The following is a description of a gene set: species: Homo sapiens Human Gene Set: chr9q21, and this is the list of marker genes: SNORA70, PCA3, LINC02872, RN7SL570P, DPP3P2, ASS1P3, RNU6-1035P, RPL24P8, BANCR, GNA14-AS1, IGKV1OR-3, LINC01507, HNRNPK-AS1 (HNRNPK antisense RNA 1), ENSG00000306036, FXN, RFK, RNU2-5P, ENSG00000227809, BMS1P13, TRPM6, RN7SL422P, ZNG1E, SPATA31A3 (SPATA31 subfamily A member 3), BMS1P12, RNU6-1303P, LINC03025, GKAP1 (G kinase anchoring protein 1), RNA5SP287, ZNF658, RN7SKP47, C9orf153, RNU6-820P, CYP1D1P, DAPK1-IT1, CYP4F59P, BTF3P4, RMI1, UBE2V1P10, GDA, AQP7P3, APBA1, OSTF1, RPL35AP21, SNX18P4, ABHD17B, RN7SL787P, PHB1P7, RORB-AS1, RAB28P4, RPSAP9, CDRT15P12, RBM17P2, RPS19P6, SMC5, RPSAP75, ENSG00000290970, SPATA31D5P, RNU6-1228P, RPL21P84, C9orf57, UBQLN1, LINC01506, SPATA31B1P, KLF9, ENSG00000308298, TLE4 (TLE family member 4, transcriptional corepressor), UBQLN1-AS1, ANXA1, MTCO1P51, RPS20P24, NFYCP2, RNU2-36P, FAM27E3, VPS13A-AS1, STK33P1 (NCBI Gene Id 553118), CDC20P1, SDR42E1P4, RN7SKP59, CNTNAP3P2, NPAP1P6, TMC1, ZNG1DP, TUT7, ENSG00000301585, TRPM3, LINC02893, IDNK, ISCA1, MTCO3P40, C9orf40, FOXB2, GOLM1, RN7SKP264 (RN7SK pseudogene 264), PGM5, FRMD3-AS1, ENTREP1, GAS1RR, TJP2, RPS27AP15, AGTPBP1, ENSG00000227463, ENSG00000290579, CDCA7P2, GAS1, MIR204, FAM74A3, ATP5F1AP10, CFAP95-DT, PIGUP1, PCSK5, SPATA31D2P, PGM5-AS1, MAMDC2, SPATA31D1, ENSG00000260995, H3P32, CEMIP2, ENSG00000303186, LYPLA2P3, RORB, LNCARSR, TLE1-DT, LINC01504, SPATA31D4, HNRNPK, ENSG00000293277, HSPB1P1, CTSL, FAM27B (family with sequence similarity 27 member B), DDX10P2, ENSG00000308124, CEP78, QNG1, RPS20P25, EIF3JP3, LINC01474 (NCBI Gene Id 101927258), GNA14, CTSL3P, TMEM252, OTX2P1, ZFAND5, MTND2P8 (NCBI Gene Id 100873178), SLC28A3, RNU6-445P, GCNT1, IGKV1OR9-1, GNAQ, KRT18P24, PRUNE2, FOXD4L4, PSAT1, FOXD4L3, KIF27, RBM22P5, ENSG00000297474, FKBP4P8, LINC02834, TMEM252-DT, RNA5SP286, MIR7-1, ENSG00000233178, NMRK1, TLE1, ENSG00000289166, NAA35, MTND2P9, RNU4-29P, ENSG00000303235, ENSG00000200969, ATP5MFP3, ZNG1C, PRKACG, ENSG00000287329, ALDH1A1, FOXD4L5, NTRK2, RNU6-368P, DAPK1, PABIR1 (NCBI Gene Id 116224), RN7SKP242, GXYLT1P4, SLC28A3-AS1, CFAP95 (cilia and flagella associated protein 95), C9orf85, RN7SL726P, CARNMT1-AS1, ANKRD20A3P, RNA5SP285, MAMDC2-AS1, RNU6-538P, RASEF, RNU4-15P, FRG1KP, CHCHD2P9, ENSG00000299547, NPAP1P4, ENSG00000289993, PIP5K1B, ENSG00000293609, NUTF2P3, ANKRD20A1, ENSG00000294531, ENSG00000293607, PTAR1, SPATA31D3, CARNMT1, RFC5P1, RBPJP2, VPS13A, FRMD3 (FERM domain containing 3), RPS6P12, PPIAP87